Given this list of marker genes ARFGEF1, PSD, AP2B1, PFN1, ADAMTSL3, GRHL3, USP13, CORO2A, FAM13B, DTX1, TPGS2, PIM1, FLI1, TAF15, ZEB2 (NCBI Gene Id 9839), MRTFA, RASGRP2, here is a description of the gene set: Genes having at least one occurrence of the motif RRMSWGANWYCTNRAGCGKRACSRYNSM in the regions spanning 4 kb centered on their transcription starting sites. This matches the PAX5 transcription factor binding site V$PAX5_02 (v7.4 TRANSFAC). Human Gene Set: PAX5_02 studied in species Homo sapiens